The following is a description of a gene set: studied in species Homo sapiens Human Gene Set: GOMF_G_PROTEIN_COUPLED_NEUROTRANSMITTER_RECEPTOR_ACTIVITY Combining with a neurotransmitter and transmitting the signal across the membrane by activating an associated G-protein; promotes the exchange of GDP for GTP on the alpha subunit of a heterotrimeric G-protein complex., and this is the list of marker genes: ADRB1, GABBR1, GRM1, CHRM1, CHRM2, CHRM3, KCTD16, CHRM5, GABRB1, GPR158, CHRM4